The following is a description of a gene set: species: Mus musculus A protein complex that possesses magnesium-dependent protein serine/threonine phosphatase (AMD phosphatase) activity, and consists of a catalytic subunit and one or more regulatory subunits that dictates the phosphatase's substrate specificity, function, and activity. Mouse Gene Set: GOCC_PROTEIN_PHOSPHATASE_TYPE_1_COMPLEX, and this is the list of marker genes: Ppp1r3c, Shoc2, Ppp1r3d, Wdr82, Ppp1r12a, Ppp1r15b, Ppp1ca, Ppp1r15a, Ppp1cb, Ppp1ccb, Mras, Ppp1r3b, Nck1, Ppp1r3a (NCBI Gene Id 211659), Ppp1r10, Ppp1cc, Tox4, Ppp1r3g, Ppp1r3e, Ppp1r3f